Given this list of marker genes IL6ST, TGFB2, SRC, POGLUT1, GDF2, CCN3, FGF10, BMP2K, MFNG, JAG1, RFNG, CNTN6, ENHO, NOTCH2NLB, EPN2, TSPAN5, KIT, HES1, TM2D3, ROBO2, DLL4, WNT1, AAK1, NOTCH1, ROBO1, SLC35C2, YAP1, MESP1, NOS3, TP63, LFNG, NOD2, TSPAN14, MIR126, JAG2, GATA5, ITGB1BP1, MIR212, GSX2, ASCL1, DLL1, NEPRO, PRKCI, ZMIZ1, STAT3, NOTCH2NLC, HES5, ACVRL1, NOTCH2NLA, PDCD10, here is a description of the gene set: Any process that activates or increases the frequency, rate or extent of the Notch signaling pathway. studied in species Homo sapiens Human Gene Set: GOBP_POSITIVE_REGULATION_OF_NOTCH_SIGNALING_PATHWAY